Given this list of marker genes HSD17B4, UGDH, ALOX5AP, ALOX15B, PTGIS, HSD17B7, MGST2, CYP2J2, HPGD, ACOX1, PCBD1 (pterin-4 alpha-carbinolamine dehydratase 1), FDXR, LTA4H, ALOX5, SCP2, AGPAT2, AKR1C3, HSD17B1, ALOX15, PTGDS, COLGALT2, here is a description of the gene set: Human Gene Set: MODULE_327 Genes in the cancer module 327. species: Homo sapiens